The following is a description of a gene set: Mouse Gene Set: GOBP_MEMBRANE_FUSION The membrane organization process that joins two lipid bilayers to form a single membrane. studied in species Mus musculus, and this is the list of marker genes: Chmp2a, Doc2b, Gas6, Vcpip1, Stx17, Spg11, Vamp2, Huwe1, Rab7, Tgfbrap1, Chmp1b2, Rubcnl, Cplane2, Syt13, Bnip1, Stx16 (syntaxin 16), Samd9l, Cd9 (CD9 antigen), Tmem95, Rab14, Yipf4, Anxa2, Eea1, Vps4a, Diaph3, Hyal5, Spaca6, Vamp9, Nectin2, Septin8, Plekhm2, Izumo1, Stx2, Doc2g, Yipf7, Chmp5, Stx18, Anxa1, Chmp1b, Rab3a, Slamf1, Rab7b, Rph3a, Tpst2, Hyal2, Erc1 (NCBI Gene Id 78063), Sox30 (SRY (sex determining region Y)-box 30), Cplx4, Pla2g5, Snapin, Chmp3, Ch25h (NCBI Gene Id 12642), Cln3, Bet1l, Rph3al, Pip4k2a, Plekhm1, Vti1a, Rab39, Syt11, Dcst2 (NCBI Gene Id 329702), Uvrag, Stx1a, C2cd5, Ubxn2b, Cplx2, Atp13a2, Mymk, Vamp4, Dysf, Lyzl4, Snap25, Syt3, Syt7, Vav3, Chmp7, Tbc1d4, 4930451I11Rik, Cav2, Syt2, Snap23, Sphk1, Snph, Itga3, Vps39, Vamp1, Pip4k2b, Gnai3, Tmem175, Syt9, Adam1a, Gosr2, Dcst1, Rufy1, Snap47, Vps11, Izumo1r, Prrt2, Dnm1l (NCBI Gene Id 74006), Stx8, Stx6, Spesp1, Pikfyve (phosphoinositide kinase, FYVE type zinc finger containing), Nkd2, Vamp8, Chmp1a, Hace1, Ankrd27, Stx5a, Spaca3, Dcstamp, Spaca5, Kif5b, Arl8b, Trarg1, Syt8, Rab8a, Grik5, Bet1, Bloc1s6, Stxbp1, Znrf1, Stx7, Stx3, Pla2g4a, Syt4, Stx19, Erc2, Catsper1, Spata46, Cplx3, Anxa7, Ykt6, Stx12, Vti1b, Chmp4b (NCBI Gene Id 96954), Glipr1l1, Vamp3, Stx4a, Spam1, Ankfy1, Rims1, Snap29, Coro1a, Wdr54, AU040320, Myof, Sec22b, Mymx, Yipf5, Sppl2c, Rab4b, Stxbp6, Rimbp2 (RIMS binding protein 2), Cacna1b, Chmp4c, Stx1b, Rab20, Lyzl6, Frey1, Snca, Rufy4, Folr2, Chp1, Syt5, Llcfc1, Opa1, Nsfl1c, Ubxn2a, Tom1, Folr1, Rab34, Gosr1, Vps33b, Rims2, Fer1l5, Uso1, Vps8, Chmp6, Stx11, Znrf2, Trim9, Tie1, Adam8, Eqtn, Cltrn, Cplx1 (NCBI Gene Id 12889), Chmp2b, Vps41, Doc2a, Syt1